Given this list of marker genes Sufu, Ift140, Runx2, Rab34, Sall3, Foxa2, Ttbk2, Arl6, Ttc21b, Chsy1, Isl1 (NCBI Gene Id 16392), Wnt7b, Tmed2, Pdcl, Prkacb, Mks1, Mgrn1, Intu, C2cd3, Actrt1, Cd3e, Traf3ip1, Ttc23, Armc9, Shox2, Fgfr2, Wdr11, Dync2h1, Ndst1, Serpine2, Fgfr3, Kctd21, Ctnna1, Rpgrip1l, Gpr37l1, Evc, Fgf10, Por, Scube2, Rab23, Fuz, Ptch2, Foxa1, Skor2 (NCBI Gene Id 664805), Prkaca, Mosmo, Wnt9a (wingless-type MMTV integration site family, member 9A), Prrx2, Fbxl17, Cibar1, Kctd11, Prrx1, Megf8, Gli2, Gli3, Ubr5, Rfx4, Sall1, Kctd6, Stk36, Herc4, Gas1, Tctn1, Efcab7, Tubd1, Glis2, Gli1, Ift81, Gpr161, Fgf9, Sfrp1, Cplane2, Rora, Scube1, Gpc3, Ihh, Cdk20, Ulk3, Dlg5, Tedc2, Enpp1 (ectonucleotide pyrophosphatase/phosphodiesterase 1), Ift172 (NCBI Gene Id 67661), Dhh, Kif7, Iqce, Uchl5, Zic1, Ptch1, Vcp, Rb1, Ift122, Rack1, Gorab, Scube3, Shh, Gas8, Hhip, Tedc1, Txndc15, Tulp3, Smo, here is a description of the gene set: Mouse Gene Set: GOBP_REGULATION_OF_SMOOTHENED_SIGNALING_PATHWAY Any process that modulates the frequency, rate or extent of smoothened signaling. species: Mus musculus